The following is a description of a gene set: Genes having at least one occurence of the motif GTTATAT in their 3' untranslated region. The motif represents putative target (that is, seed match) of human mature miRNA hsa-miR-410 (v7.1 miRBase). species: Homo sapiens Human Gene Set: GTTATAT_MIR410, and this is the list of marker genes: CSNK1G1, CPEB3, CBFB, CBX4, HERC4, RPS6KA5, NRXN3, MACF1, YAF2, CPSF6, MSTN, MYLIP, FMR1, PHF20L1, MSL2, CPEB4, FGF7P6 (fibroblast growth factor 7 pseudogene 6), MINAR1, LAMP2, BAZ2B (bromodomain adjacent to zinc finger domain 2B), TMEFF2, NR3C1, FCHO2, MAP4K5, DACH1, IP6K1, ITCH, QKI, DTNA (NCBI Gene Id 86552), RDX, MOB1B, ANKRD12, FMNL2, CREB5, PRKAR2B, PHF6, SYN2, ST8SIA4, HMGB1, SCAMP5, PCDH8, CITED2, ST18, DOCK9, NEXMIF, CHD7, RAB8B, NUMB, ETS1, OR51E2, ADM, C11orf87, NTRK2, TEAD1, TNFSF11, ZZZ3, FGF7P3, HS3ST1, ARID4B, NR2F2, TNRC6B, ARID2, TENT4A, RAI14, ATP2B2, TAFA5, SP3, MFSD14A, ATG16L1, SP4, RAB1A, OTX2, ADAM10, GRIA2, SMAD7, ITPKB, MAF (NCBI Gene Id 4094), MSI2, RGS16, RAI1, YIPF4, ARK2N, CASK, DPYSL2, COPS7B, KAT6A, FBXO33, RERE, GDF6, C16orf87, FGF7, YY1, SOX1